The following is a description of a gene set: from publication Chen Y, Wang X (PMID 31504780) Genes predicted to be targets of miRBase v22 microRNA mmu_miR_412_3p in miRDB v6.0 with MirTarget v4 prediction scores > 80 (high confidence targets). species: Mus musculus Mouse Gene Set: MIR_412_3P, and this is the list of marker genes: Abca5, Ehd4, Hnf4g, Arrdc3, Ell, Hipk3, Katnbl1, Snx12, Gpr55, Ppt1, Hnrnpll, Zfp764, Uncx (NCBI Gene Id 22255), Mknk2, Shank2, Xkr7, Tmprss13, Rab39b, Polr3g, Ift57, Otud7b (NCBI Gene Id 99649), Zfp148, Inafm2, Ehf, Rab8b, Ehd3, Srsf2, Kbtbd8, Hmox2, Khdc1b, Igsf9, Bach1, Supt16, Clock, Nufip1, Osbpl7, Sv2b, Mapk9, Lyn, Rims2, Gpd2, Poc1b, Tmem178b, Wtap, Zfp516, Ppp6r3, Pcsk2, Klra8, Ube2d2a, Spty2d1, Impa2, Cmtm4, Nfatc3, Fxn, Lpin2, Mthfsd, Ifnlr1, Chst1, Prb1b, Usp7, Foxf1, Slfn9, Hif1an, Seh1l (SEH1-like (S. cerevisiae), Pou3f4, Fzd3